The following is a description of a gene set: from publication Chen Y, Wang X (PMID 31504780) Genes predicted to be targets of miRBase v22 microRNA hsa-miR-4293 in miRDB v6.0 with MirTarget v4 prediction scores > 80 (high confidence targets). species: Homo sapiens Human Gene Set: MIR4293, and this is the list of marker genes: CPEB3, RNF19A, BPTF, WEE1, EPHA10, FUS, AQP3, MED8, FGL2, PECAM1, ZFPM2, ABHD17C, CLIP3, KPNA1, MTUS1, RANBP17, ZBTB10, VPS26A, CLEC14A, PIAS3, CNOT6L, SIAH1, SETD7, RPL36A, RAP1B, SLAIN2, RGS17, EDC3, CHD1, ADGRB3, CASD1, LGALSL, BHLHE40, TAB2, MTCL3, WDR47, CYB5D1 (cytochrome b5 domain containing 1), CYP20A1, HOXA13, SORCS3, THUMPD3, PANK2, ZNF264, DUSP13A, ZNF546, LIPT2-AS1, METTL8, CSMD1, DCAF7, SYNJ2BP, ARMC3, TOX3, ARFGEF1, ARL6IP6, ARSF, AZIN1, PELI1, RFX3, GLCE, MLPH, PRKAG2, CAPRIN2, RAB2B, HECW1, PTGS1, HEMGN, HDAC1, CXXC4, YAP1, AIG1, ZNF655, EIF3J, MTFR1, OLFML3, ZFYVE28, SLC24A2, LEMD2, ARHGAP24 (NCBI Gene Id 83478), ZNF528 (zinc finger protein 528), RNF17, MEX3C, SREBF2 (NCBI Gene Id 6721), GLG1, ZDBF2, SKIDA1, VOPP1, ZBED4, MTF1, DUSP7, TRAF3IP2, WAPL, ABHD16A, RNF144B, ZNF451, TANC2, REG3G (NCBI Gene Id 130120), SLC30A6, LONP2, DESI2, RAB4A, LMO4, NFATC4, GGNBP2, GSKIP, DCUN1D1, ADGRA3 (NCBI Gene Id 166647)